The following is a description of a gene set: species: Mus musculus Mouse Gene Set: GOBP_POSITIVE_REGULATION_OF_HORMONE_METABOLIC_PROCESS Any process that activates or increases the frequency, rate or extent of the chemical reactions and pathways involving any hormone., and this is the list of marker genes: Igf2, Hif1a, Bmp6, Por, Ctns, Rdh19, Igf1, Cyp17a1, Rdh16f2, Egr1, Wnt4, Nr5a2, Arnt, Slco1c1, Rdh1, Gata3, Rdh10, Dab2, Hpn, Lhcgr, Rdh9, Rdh16, Gh, Igf1r, Pax8, Ppargc1a